Given this list of marker genes IVD (NCBI Gene Id 3712), MCCC2, AUH, HMGCL, HMGCLL1, MCCC1, ACADM, here is a description of the gene set: Leucine degradation. Pathway ID: N00851. Pathway type: Reference. Pathway class: nt06024 Valine, leucine and isoleucine degradation. Pathway Definition from KEGG: IV-CoA -- (IVD,ACADM) >> MCCC1/2 >> AUH >> (HMGCL,HMGCLL1) -> AcCoA species: Homo sapiens Human Gene Set: KEGG_MEDICUS_REFERENCE_LEUCINE_DEGRADATION